Given this list of marker genes RYR2, SDHA, NONO, RNU4ATAC, SDHB, TPM1, TBX5, DHX9, DTNA, SDHAF1, MYSM1, MLYCD, CRLS1, DNAJC19, SDHD, MYOCD, MIB1, MYL2, here is a description of the gene set: A type of cardiomyopathy characterized anatomically by deep trabeculations in the ventricular wall, which define recesses communicating with the main ventricular chamber. Noncompaction cardiomyopathy species: Homo sapiens Human Gene Set: HP_NONCOMPACTION_CARDIOMYOPATHY